Given this list of marker genes SCN2B, INHBB, UBA52, CPOX, MAP1B, CYP1A1, CCNB1 (NCBI Gene Id 891), FECH, here is a description of the gene set: studied in species Homo sapiens Any process that results in a change in state or activity of a cell or an organism (in terms of movement, secretion, enzyme production, gene expression, etc.) as a result of an insecticide stimulus. Insecticides are chemicals used to kill insects. Human Gene Set: GOBP_RESPONSE_TO_INSECTICIDE